Given this list of marker genes NAT1, RET (ret proto-oncogene), AKR7A3, SREBF1, PNMA1, PDGFD, CSRP2, NDUFAF4, FAM234B, RBM47, ACOT2, HEBP2, GMPS, GSTP1, FASN, BCL11A, SLC16A6, SLC9A6, PPP1CB, YBX3, RSU1, SLC2A10, U2SURP, TOB1, TSPAN1, KDM4B, MYC, EFHC1, VPS37C, CPD (carboxypeptidase D), TPX2, CX3CL1, NME3, RGS5, LONP2, ASF1A, MCM5, AHNAK, MID1, CACNA2D2, SLC43A3, SLC44A4, TESMIN, TBC1D9, MAGED2, KIF4A, IRS1, NT5C2, PAAF1, ADD2, ADIRF, SCNN1A, EVL, GTPBP4, CD44, KRT16, NQO1, COX16, KIF16B, PLIN2, DHRS2, LBR, CYP2B7P, CLCN4, PEX11A, SLC49A3, ST8SIA1, AMACR, PRNP, GPR161, GATA3, QKI, TMEM123, CHI3L1, CXCL8, H1-1, IL6ST, SLC22A18, GABBR2, PELI1, TFF1, VGLL1, DSC3, GAL, ATP7B, RABEP1, HSD17B4, RALGAPA1, MYO10, FBXL7, CHEK1, KLF5, RNF43, PTGER3, SPTLC2, MAGOH, UGCG, APBB2, BCL2, MELK, DNAJC12, CA12, P4HTM, TPBG, NHERF1, YBX1, TTK, GPM6B, LIMA1, MRTFB, LRRC17, LRRC8D, ABAT, CORO1C, ATG5, PRR15L, KRT8, GAMT, CLIC4, SERPINA5, IFRD1, CDC20, LMO4, TBC1D12, BBS1, DALRD3, CYP2B6, GALNT7, ARHGEF9, GSE1, MAPT, TRMT11, CILP, LRBA, TUBB6, KLHL7, NRTN, DNALI1, BCL2A1, BTG3, RARA, WDR19, GPC1-AS1, TSPAN13, DCXR, SEMA3C, RAD51AP1, GALNT6, PDZK1, MYB, CCL2, TSC22D3, BUB1 (NCBI Gene Id 699), DSC2, FOXC1, REEP5, CEBPG, SKP2, KRT6B, DMD, SLC2A5, TOM1L1, ST6GALNAC2 (ST6 N-acetylgalactosaminide alpha-2,6-sialyltransferase 2), MCM10, GABRP, LDHB, PKP1, ECI2, PFKP, CHMP2A, CPB1, ITGB5, NFE2L3, PBX1, PUM3, NDC80, SCHIP1, DKC1, GDF15, LASP1, FAM171A1, SOD2, DACH1, PRKX, GLS, SEMA3F, RND1, MTHFD2, MTMR2, SCCPDH, S100B, CELSR1, ESR1, SPATA20, TFF3, PLAAT1, SPDEF, MYO5C, NCK1, TCF7L1, SRPK1, CCNE1, RHOB, FABP5, MMP12, SCUBE2, WWP1, MPZL2, GSTZ1, ELAPOR1, ACADSB, FAM174B, NFIB, MICALL1, ERBB4, FOXM1, GFRA1, PHGDH, AMD1 (NCBI Gene Id 262), AP1AR, TRIM29, INPP4B, BLVRA, E2F3, HHAT, SIDT1, UGT8, KIAA0232 (NCBI Gene Id 9778), PRKAR1A, CDK17, CHST2, HSPB1, MLPH, PSME4, CANT1, PTX3, EIF1AX, PTTG1, HDAC2, WFS1, GPD1L, SYBU, ART3, FBXL5, PI3, SEPHS1, SNRPD1, AR, CRIP1 (NCBI Gene Id 1396), ARMT1, CDKN2A, CXCL5, CERS6, MARCO, NUDT4, BBOF1, SMCO4, CCNC, CAPN9, TFAP2A, TTC39A, ANXA9, KRT6A, TGFB3, SYNC, BBOX1, NBEA, NFIL3, PALS2, KRT18, SLC35E2B, FMO5, ADM, SYNCRIP, TCEAL4, VEZF1, PRDX4, IGF2BP2, CIRBP, REEP1, TM7SF2, STEAP3, CD24P2, ACTL6A, RIF1, FBP1, LRP12 (NCBI Gene Id 80002), RETSAT, TRIM2, GALNT10, FUT8, ALDH6A1, CEBPB, EFCAB11, TTLL4, CASP8AP2, LYN, SPRED2, HS3ST1, TMEM135, PDSS1, SLC16A1, FYCO1, TBX3, RARRES1 (retinoic acid receptor responder 1), CENPA, IGFBP4, MSN, AREG, GSTM3, PRKD3, YEATS2 (YEATS domain containing 2), EN1, SERHL (serine hydrolase like (pseudogene)), SLC39A6, TCEAL1, LGALS8, AGR2, MCCC2, SLC19A2, MACIR, DNAJC1, MRFAP1L1, KIF14, RNF138, APPBP2, GREB1, STIL, DHRS7, here is a description of the gene set: Previous microarray studies on breast cancer identified multiple tumour classes, of which the most prominent, named luminal and basal, differ in expression of the oestrogen receptor alpha gene (ER). We report here the identification of a group of breast tumours with increased androgen signalling and a 'molecular apocrine' gene expression profile. Tumour samples from 49 patients with large operable or locally advanced breast cancers were tested on Affymetrix U133A gene expression microarrays. Principal components analysis and hierarchical clustering split the tumours into three groups: basal, luminal and a group we call molecular apocrine. All of the molecular apocrine tumours have strong apocrine features on histological examination (P=0.0002). The molecular apocrine group is androgen receptor (AR) positive and contains all of the ER-negative tumours outside the basal group. Kolmogorov-Smirnov testing indicates that oestrogen signalling is most active in the luminal group, and androgen signalling is most active in the molecular apocrine group. ERBB2 amplification is commoner in the molecular apocrine than the other groups. Genes that best split the three groups were identified by Wilcoxon test. Correlation of the average expression profile of these genes in our data with the expression profile of individual tumours in four published breast cancer studies suggest that molecular apocrine tumours represent 8-14% of tumours in these studies. Our data show that it is possible with microarray data to divide mammary tumour cells into three groups based on steroid receptor activity: luminal (ER+ AR+), basal (ER- AR-) and molecular apocrine (ER- AR+). Human Gene Set: FARMER_BREAST_CANCER_BASAL_VS_LULMINAL from publication Farmer P, Bonnefoi H, Becette V, Tubiana-Hulin M, Fumoleau P, Larsimont D, Macgrogan G, Bergh J, Cameron D, Goldstein D, Duss S, Nicoulaz AL, Brisken C, Fiche M, Delorenzi M, Iggo R (PMID 15897907) Genes which best discriminated between two groups of breast cancer according to the status of ESR1 and AR: basal (ESR1- AR-) and luminal (ESR1+ AR+). studied in species Homo sapiens